The following is a description of a gene set: Reactome Pathway: Non-canonical inflammasome activation The human genome encodes the inflammatory caspase-1 (CASP1), CASP4, CASP5, and CASP12. CASP1 activation requires inflammasomes such as NLRP3 or NLRC4, whereas CASP4 and CASP5 are directly activated by binding cytosolic lipopolysaccharide (LPS), a key component of the outer membrane of Gram-negative bacteria, forming non-canonical inflammasomes (Shi J et al., 2014; Casson CN et al., 2015; Christgen S et al., 2020). The term “non-canonical inflammasome” was first introduced for CASP11, the murine ortholog of human CASP4 and CASP5, which mediates signaling distinct from the classical CASP1-driven inflammasome (Kayagaki N et al., 2011). Intracellular LPS activates Casp11 independently of Toll-like receptor 4 (TLR4) (Kayagaki N et al., 2013; Hagar JA et al., 2013), and Casp11, along with its human orthologs CASP4 and CASP5, functions as a direct receptor for cytosolic LPS (Shi J et al., 2014). Upon activation, inactive caspase monomers oligomerize to form dimeric structures where the protease domains of the two monomers are aligned in an anti-parallel orientation. This dimerization leads to a conformational change that exposes the catalytic site, autoproteolytically activating the caspase.<p>Activated CASP1, CASP4, CASP5 and murine Casp11 cleave the linker domain of gasdermin D (GSDMD), generating N- and C-terminal fragments (Shi J et al., 2015; Kayagaki N et al., 2015; Liu X et al., 2016). The N-terminal fragment of GSDMD oligomerizes and inserts into cellular membranes to form pores, leading to cell swelling and membrane rupture, a hallmark of pyroptosis (Liu X et al., 2016; Ding J et al., 2016; Sborgi L et al., 2016; Aglietti RA et al., 2016). Unlike CASP1, which efficiently processes pro-IL-1β and pro-IL-18 to generate their mature, biologically active forms, both CASP4 and CASP5 preferentially activate pro-IL-18 and inactivate IL-1β (Shi X et al., 2023; Exconde PM et al., 2023; Devant P et al., 2023; reviewed by Exconde PM 2024). The mature cytokines of IL-1 family are secreted through GSDMD pores, thereby amplifying the inflammatory response in mammals (Shi J et al., 2015; Kayagaki N et al., 2015; reviewed by Broz P et al., 2020; Liu X et al., 2021). CASP4- and CASP5-mediated pyroptosis can also lead to secondary activation of the NLRP3 inflammasome, further enhancing CASP1 activity (Schmid-Burgk JL et al., 2015; Baker PJ et al., 2015).<p>CASP5 expression is low under basal conditions but is strongly upregulated by inflammatory stimuli such as bacterial LPS and IFNγ, particularly in immune cells. In contrast, both CASP1 and CASP4 are constitutively expressed in a tissue and cell type specific manner, with high expression detected in lung, spleen, and colon, and can also be upregulated during inflammation (Lin XY et al., 2000; Feng Q et al., 2004; Eckhart L et al., 2006; Viganò E et al., 2015). In human peripheral blood mononuclear cells (PBMCs), LPS stimulation results in a >10-fold increase in CASP5 expression levels, a greater induction than that observed for CASP1 or CASP4 (Eckhart L et al., 2006). Although CASP4 and CASP5 share overlapping mechanisms, such as activation by cytosolic LPS and processing of similar substrates, their distinct expression patterns and potential differences in substrate affinity suggest non-redundant roles in innate immunity and disease-specific contexts (Ghait M et al., 2023; Cheng Y et al., 2023; Shi X et al., 2023; Exconde PM et al., 2023, 2024). CASP12 is also classified as an inflammatory caspase, though its physiological role remains poorly understood (Di Sano F et al., 2006; Salvamoser R et al., 2019).<br> studied in species Homo sapiens part of: Innate Immune System, and this is the list of marker genes: SERPINB1, GBP3, CALM3, IL18, IL1B, ospC3, CASP4, GBP1, CASP5, CALM2, GSDMD, CASP3, GBP4, CALM1, GBP2